Given this list of marker genes Rxrb, Ncoa1, Ncor2, here is a description of the gene set: studied in species Mus musculus This event has been computationally inferred from an event that has been demonstrated in another species.<p>The inference is based on the homology mapping from PANTHER. Briefly, reactions for which all involved PhysicalEntities (in input, output and catalyst) have a mapped orthologue/paralogue (for complexes at least 75% of components must have a mapping) are inferred to the other species. Reactome Pathway: NR1H2 & NR1H3 regulate gene expression to control bile acid homeostasis part of: NR1H2 and NR1H3-mediated signaling electronically inferred by orthology from the curated human pathway